The following is a description of a gene set: Human Gene Set: GOBP_FEMALE_MEIOSIS_CHROMOSOME_SEGREGATION species: Homo sapiens The cell cycle process in which genetic material, in the form of chromosomes, is organized and then physically separated and apportioned to two or more sets during the meiotic cell cycle in a female., and this is the list of marker genes: PLK1, TTK, NCAPH, MLH1, MEIKIN, NCAPH2